Given this list of marker genes Nod1, Tlr3, Mapkapk2, Pycard, Myd88, Laptm5, Psg22, Ticam1, Wnt5a, Casp1, Mir324, Sema7a (NCBI Gene Id 78407), Tlr4, Tlr2, Gprc5b, Tlr7, Ifng, Tirap, Cd36, Spon2, Casp4, Nod2, Cd74, Plcg2, H2-M3, Sirt1 (NCBI Gene Id 93759), Card9, Rtn4, P2rx7, Ripk2, Panx1, here is a description of the gene set: Any process that increases the rate, frequency or extent of macrophage cytokine production. Macrophage cytokine production is the appearance of a chemokine due to biosynthesis or secretion following a cellular stimulus, resulting in an increase in its intracellular or extracellular levels. Mouse Gene Set: GOBP_POSITIVE_REGULATION_OF_MACROPHAGE_CYTOKINE_PRODUCTION studied in species Mus musculus